Given this list of marker genes RGS2, SGPP1, ADD3, TOB2, CEBPD (NCBI Gene Id 1052), EGLN3, ID3, MSLN, FDX1, PXYLP1, PDE8B, ERRFI1, TENM4, FNDC3A, KITLG (NCBI Gene Id 780897), PRRX1, SIPA1L2, RNF144A, SIX1, VIP, ID2, PLOD2, ENO2, XDH, RAMP3, CDH26, ALCAM, NR3C1, GAS2, here is a description of the gene set: Human Gene Set: WOTTON_RUNX_TARGETS_DN from publication Wotton S, Terry A, Kilbey A, Jenkins A, Herzyk P, Cameron E, Neil JC (PMID 18560354) Common target genes down-regulated by all three Runx family members (RUNX1, RUNX2, and RUNX3) in MEF cells (embryonic fibroblasts). species: Mus musculus The Runx genes are important in development and cancer, where they can act either as oncogenes or tumour suppressors. We compared the effects of ectopic Runx expression in established fibroblasts, where all three genes produce an indistinguishable phenotype entailing epithelioid morphology and increased cell survival under stress conditions. Gene array analysis revealed a strongly overlapping transcriptional signature, with no examples of opposing regulation of the same target gene. A common set of 50 highly regulated genes was identified after further filtering on regulation by inducible RUNX1-ER. This set revealed a strong bias toward genes with annotated roles in cancer and development, and a preponderance of targets encoding extracellular or surface proteins, reflecting the marked effects of Runx on cell adhesion. Furthermore, in silico prediction of resistance to glucocorticoid growth inhibition was confirmed in fibroblasts and lymphoid cells expressing ectopic Runx. The effects of fibroblast expression of common RUNX1 fusion oncoproteins (RUNX1-ETO, TEL-RUNX1 and CBFB-MYH11) were also tested. Although two direct Runx activation target genes were repressed (Ncam1 and Rgc32), the fusion proteins appeared to disrupt the regulation of downregulated targets (Cebpd, Id2 and Rgs2) rather than impose constitutive repression. These results elucidate the oncogenic potential of the Runx family and reveal novel targets for therapeutic inhibition.